Given this list of marker genes KIAA0319L, OBSL1, FIG4, RNU4ATAC, RUNX2, CCR6, MATN3, SMAD4, FRAS1, CPLX1, HSPG2, WNT7A, HNRNPR, SIK3, CCDC8, COL11A2, GJB2 (NCBI Gene Id 2706), HLA-DRB1, FGFR2, NELFA, CCN2, IRF5, CAV1, INTU, FLNA, INPPL1, CBFB, KAT6B, ABCC9 (ATP binding cassette subfamily C member 9), CUL7, CTBP1, NKX3-2, SETBP1, FREM2, COL2A1, BMP1, ATP7A, TBX15, PIGG, LETM1, GSC, GRIP1, DYM, GJB6, NSD2, here is a description of the gene set: An anomaly of the the pubic bone, i.e., of the ventral and anterior of the three principal components (pubis, ilium, ischium) of the hip bone. Abnormal pubic bone morphology species: Homo sapiens Human Gene Set: HP_ABNORMAL_PUBIC_BONE_MORPHOLOGY